The following is a description of a gene set: Human Gene Set: GSE3565_CTRL_VS_LPS_INJECTED_SPLENOCYTES_DN species: Homo sapiens Activation of the Mitogen activated protein kinase (MAPK) cascade following Toll-like receptor (TLR) stimulation enables innate immune cells to rapidly activate cytokine gene expression. A balanced response to signals of infectious danger requires that cellular activation is transient. Here, we identify the MAPK phosphatase Dual specificity phosphatase-1 (DUSP1) as an essential endogenous regulator of the inflammatory response to LPS. DUSP1-deficient (DUSP1-/-) bone marrow derived macrophages showed selectively prolonged activation of p38 MAPK and increased cytokine production. Intraperitoneal challenge of DUSP1-/- mice with LPS caused increased lethality and overshooting production of IL-6 and TNF-alpha. Transcriptional profiling revealed that DUSP1 controls a significant fraction of LPS-induced genes, that includes IL-6 and IL-10 as well as the chemokines CCL3, CCL4 and CXCL2. In contrast, the expression of the important mediators of endotoxin lethality, IFN-gamma and IL-12, was not significantly altered by the absence of DUSP1. These data together demonstrate a specific regulatory role of DUSP1 in controlling a subset of LPS-induced genes that determines the outcome of endotoxin shock. from publication Hammer M, Mages J, Dietrich H, Servatius A, Howells N, Cato AC, Lang R (PMID 16380512) Genes down-regulated in spleen from wildtype mice: control versus LPS., and this is the list of marker genes: FOXO1, GRK6, RHOH (ras homolog family member H), LTB, RAPGEF6, CCDC28B, ST6GAL1, TFRC, TGFBR3, PATJ, GSTT2, GAR1, RAB3IP, RPL29, KLHDC2, RPL18, GPX1, ITM2A, RPS26, DUSP10, ADGRG5, RPS10, DPP4, THG1L, EXT1, MIF, TSPAN13, EEF1B2, WDR26, CTPS1, CD55, SELENOP, DGKA, DNMT3A, ID3, HOOK1, NEDD4L, PLAC8, CCNE1, CHST15, DDX21, ETV3, PLEKHA1, RTP4, EYA2, PACSIN1, RGS10, TNFSF8, SLC11A2, ENTPD5, TREML2, NONO, CTNNBL1, SARAF, MTHFD1L, MYBBP1A, NSG2, CD69, ITGAE, PRPS2, EIF3G, FBL, SMC1A, ARHGAP9, RPL8, RAPGEF4, ELOVL5, VASP, LEF1, SLC16A5, NPC2 (NPC intracellular cholesterol transporter 2), ACSF2, RPLP0, N4BP2, RACK1 (NCBI Gene Id 90938), TRIM59, COX7A2L, RPL36, VARS1, ABCG1 (NCBI Gene Id 9619), TOX, GPATCH4, STAMBPL1, SLAMF6, ICE2, PIP4K2A, LIPA, GPR146, SESN1, EEF2, KLF13, LBH, RPS3, RETREG1, MYB (MYB proto-oncogene, transcription factor), CD7, TLR1 (toll like receptor 1), MYC, KMT5B, ADAM11, USP53, FILIP1L, CARMIL2, NSMCE1, SIDT1, TEX9, EVL (Enah/Vasp-like), SMC4, ZNHIT6, PRKD2 (NCBI Gene Id 51519), INPP4B, PCBP1, ABLIM1, UBALD1, FAM78A, RCN3, FCHSD2, IFT80, AMPD1, CCR7 (NCBI Gene Id 1236), NCOA3, USP28, CD2AP, CNP, IKBKE, RPL13, IFNGR2, SATB1, SNHG1, MGST2, IL6ST, SESN3, TET1, TRIB2, PDK1, RRAS2, FAM3C (FAM3 metabolism regulating signaling molecule C), DUSP6, STT3B, RPS2, RNF144A, PIGQ (phosphatidylinositol glycan anchor biosynthesis class Q), TMEM131, RPLP1, DAPL1, ACTN1, GNAS, BICDL1, RCSD1, TCF20 (NCBI Gene Id 6942), TCF7, MDN1, TANC1, ZYG11B, ALS2CL, KBTBD11, CCR9 (NCBI Gene Id 2851), DPH5, CD3D, PITPNM2, LY6E, TBL1X, EIF4A1, FASN, PELI1, SSBP2, CCT5, RALGPS2, F2RL1, NME1, ADD1, EIF4B, PLEKHO1 (NCBI Gene Id 51177), CD27, WDR43